The following is a description of a gene set: Human Gene Set: GOBP_REGULATION_OF_MITOTIC_CELL_CYCLE_PHASE_TRANSITION studied in species Homo sapiens Any process that modulates the frequency, rate or extent of mitotic cell cycle phase transition., and this is the list of marker genes: CHFR, TPR, BRCC3, MARK3, FGF10, MIR195, BCL7B, RRM2, MNAT1, CDK5RAP2, PRP4K, HSPA2, PSMG2, BUB1, CCNB1, MIR515-1, SENP2, SLFN11, ABRAXAS1, RFWD3, ANKRD17, RPA2, ACTL6B (NCBI Gene Id 51412), DDR2, RBBP8, SPC24, RIOK2, ATM, DDX3X, WAC, ZWILCH, CDKN2B, MAD2L1BP, FOXO4, ARID2, CPSF3, ANAPC15, PABIR1, KLHL22, CDC73, SMARCA2, MRNIP, TRIP13, PKIA, STIL, RPTOR, BABAM2, RBL1, MIR214, SMARCC2 (SWI/SNF related, matrix associated, actin dependent regulator of chromatin subfamily c member 2), ANAPC4, ZC3H12D, SKA3, MEPCE, PLK5, APPL1, CHEK1, CDK1 (cyclin dependent kinase 1), AURKA, LSM11, SMARCA4, CCND2, INO80, KNL1, CACNB4, CDKN2C, STK35, PSME3, MTA3, ERCC2, MBTPS1, ACTB, CUL4A, HECW2, KNTC1, TTK, NEK6, MIR638, RAB11A, SPDL1, NABP1, PTEN, NABP2, MTBP, DLG1, CENPF, UBE2C, BRD7, FOXN3, TFDP3, DBF4B, NAE1, SMARCD1, ARID1A, CDK2, PSME1, FZR1, WEE1, ZFP36L1 (NCBI Gene Id 677), TGFB1, CTC1, CCNE2, HASPIN (NCBI Gene Id 83903), ZNF655, CUL4B, ARID1B, XPC, AKT1, DCUN1D3, DPF1, INIP, CDC14C, RINT1, HUS1B, SIRT2, SMARCC1, NEUROG1, EZH2, MIR137, MIR19B1, SKA1, KLF11, TREX1, MIR29A, MIR16-1, CDK5RAP3, AURKB, MIR133A1, TMEM14B, DUSP1, DPF3, MIR520A, PLK3, MUC1, PRMT2 (protein arginine methyltransferase 2), CHMP4C, CDC23, BRSK1, TMOD3, ACTL6A, SASS6, KMT2E, NUF2, ZNF207, FBXO5, RAD51C, PBX1, MIIP, ANAPC7, SMARCE1, INHBA, PPP1R9B, PRAP1, ZFYVE19, PHOX2B, ETAA1, RB1, FBXO31, PKD1, KIF14, PBRM1, CTDSP1, RCC2, MIR362, MIR26A1, CDK7, ACVR1, ECD, AVEN, SYF2, PTENP1-AS, DYNC1LI1, TAOK3, TRIAP1, TPRA1, RAD51B, CCNH, TERT, FBXO7, UIMC1, RGCC, DGKZ, MAD2L1, XRCC3, PRKDC, PTPN6, PPP2CA, BRCA1, TEX14, MIR372, DPF2, MIR29B1, MIR15B, CDCA5, NBN, ATR, ZWINT, RRM2B, VPS4B, RRM1, UBD, TCF3, ANLN, DTL, GFI1B, PLRG1, CUL3, CDC25C (cell division cycle 25C), LSM10, BCL7A, TAOK2, CDK3, BID, RAD50, MIR222, CCNE1, MIR30C2, RBL2, PINX1, PLCB1, NOP53, PLK1, MIR221, CDKN1A, CLSPN, PHF10, CCL2, EGFR, RAD17, KLF4, SDE2, ZNF830, KCNH5, WNT10B, SMARCB1, APC, GIGYF2, ATAD5, INCENP, PKMYT1, EIF4G1, KCNA5, PDIK1L, GEN1, RPS27L, FHL1, BLM, MBTPS2, CDCA8 (NCBI Gene Id 55143), CDC14B, GPNMB (NCBI Gene Id 10457), MIR451A, DLGAP5, JADE1, UBE2E2, HUS1, AIF1, PKD2, CENPJ, MAP3K20, MDM2, MIR15A (microRNA 15a), ANXA1, BRD4, CDC14A, CDKN1C, ERCC3, CDC20, E2F1, PSME2, USP44, MYO16, ZW10, DACT1, ADAM17, TFAP4, CDC25B, BUB1B, MIR133B, CCND3, ORC1, TICRR, CDC25A, APPL2, TRIM39, BABAM1, MIR519D, NPM2, CTDSP2, KLHL18, SMARCD2, CDKN1B, MIR520H, CDKN2A, CENPE, GTPBP4, SMARCD3, AMBRA1, CTDSPL (NCBI Gene Id 10217), BIRC5, MIR208A, TM4SF5, E2F7, CDC16, CDK2AP2, ESPL1, MIR892B, ANAPC5, RAD21, STOX1, NEK11 (NCBI Gene Id 79858), INTS3 (integrator complex subunit 3), SIN3A, BCL7C, MIR193A, BARD1, DDB1, ZFP36L2, IK, ANAPC11, CDC6, MAD1L1, MIR29C, CDK10, MBLAC1, RNASEH2B, NSMCE2, RFPL1, LCMT1 (NCBI Gene Id 51628), MRE11, HEXIM2, CDK4, CDC7, TFDP1, IER3, BTN2A2, BUB3, ID2, CDKN2D, CRLF3, MIR495, TAOK1 (TAO kinase 1), GPR132, CDK6, CCND1, BCL2, KANK2, CYP1A1, SPC25, RDX, TP53, VPS4A, NDC80, FAM107A (family with sequence similarity 107 member A), MAD2L2, DONSON, ADAMTS1, TOPBP1